The following is a description of a gene set: species: Homo sapiens from publication Chen Y, Wang X (PMID 31504780) Human Gene Set: MIR431_5P Genes predicted to be targets of miRBase v22 microRNA hsa-miR-431-5p in miRDB v6.0 with MirTarget v4 prediction scores > 80 (high confidence targets)., and this is the list of marker genes: SERINC5, CELSR2, WDR55, NMBR, CHODL, SOCS6, MOCS1, FOXJ3, LHX8, SHISAL2B, KLRG1, LIFR, SPDYA, UBE2D1, CANX (calnexin), DLX3, ZNF644, PCNP, GPC6, C1orf94, SORL1, C17orf67, ZNF143, DMGDH, DIAPH2, ERCC6, PEX5L, XRRA1, MMP28, CD34, ALG8, RALGAPB, CD69, ZEB1, APOOL, CDCP1, CNTNAP3B, CAMTA1, COL12A1 (collagen type XII alpha 1 chain), TPGS2, IRF2BP2, ST6GALNAC3 (NCBI Gene Id 256435), RIPOR2, CCDC59, ZNF280C, DNAJC21, HIPK3, DISC1, PMFBP1, POLR1F, API5, ELP1, DAAM1, PITPNA, KDM7A, ANKH, CLTC, TSPYL4, FAS, MEIOC